Given this list of marker genes NEUROG1, PTCH2, RYR1, ARMC9, NLGN4X, PTEN, SNORD115-1, NOTCH2, HOXD13, TBX5, XRCC4, ALX1, TARS1, ZIC2 (Zic family member 2), NUP85 (NCBI Gene Id 83705), INPP5E, PNPLA6, PRKD1, HNRNPH1, ORC4, GTF2E2, SAMHD1, CD19 (CD19 molecule), EIF4A2, SLC25A12, STAG2, VPS35L, CCDC22, PTCH1, AIP, MAFB, TBCD, BRIP1, TOGARAM1, PEX14 (NCBI Gene Id 5195), KRAS, NSUN2, TGFB3, TLK2, RNF216, CBFB, CHN1, TAF6, SCO2, NRAS, CDKN1C, IGF2, CCDC47, GNPTAB (NCBI Gene Id 79158), PEX6, SLC6A9, PIK3R1, ZDHHC9, TBL1XR1, SON, PPP1R12A, HK1, CDH2, SC5D, CHRNG, DIS3L2, TUBA1A, MADD, PPM1B, GATAD2B, MYCN, DSE (NCBI Gene Id 29940), POLR1C, PRIM1, MEG3, CCBE1, PEX12, HNRNPC, CILK1, FOXF1, POLR3A (NCBI Gene Id 11128), RBM8A, FLI1, PIGO, BRCA2, FRMPD4, MASP1, KDM6A, FLT4, RAB34, ATP7A, D2HGDH, ERCC5, SPTBN1, CEP104 (NCBI Gene Id 9731), DDR2, KMT2E, MAP2K2, HNRNPK, NKX6-2, NAGLU, PDHX, TONSL, ROR2, GNB2, MAP2K1 (mitogen-activated protein kinase kinase 1), SH3PXD2B, LARS1, DICER1, HMGA2, XPC, CSGALNACT1, IFT81, POLE, SUFU, AP1G1, RECQL4, HCFC1, TUBB, MAPK1, COX4I1, TNFRSF11B (TNF receptor superfamily member 11b), NSD2, OTUD6B, ROBO3, GRIA1, FLNB, EHMT1, SALL4, IFT52, CUL7, CDK10, CUX1, PCNT, TOR1A, ACOX1, FOXP2, FERMT1, SLC4A10, SERPINH1, ERCC6, PPP2R1A (NCBI Gene Id 5518), ATR, ADARB1, ATIC, TUBGCP4, CKAP2L, BRD4, B3GALT6, USB1, RREB1, ZFPM2, FUCA1, PEX19, CYFIP2, H4C9, FGFR2, SYT1, CHD5, GYPC, TCTN2 (NCBI Gene Id 79867), SPRTN, LRPPRC, LTBP4, ASH1L (NCBI Gene Id 55870), CHUK, OTUD5, HBA1, CDC45, MYH3, TMEM218, CRPPA, RAB23, SUPT16H, SYNE1, TCF20, PLA2G6, PLEC, ATP6V0A2, PIGN, PIGA, TGFBR2, NDE1, RSPRY1, TDP2, ASPM, MSX2, UPF3B, DPH1, CHD6, DMP1, KNSTRN, TNFRSF11A, IFT43, DPM1, PLK4, CEP57, CNTNAP1, PIGT, ALDH18A1, FTO, ATRIP, HIRA, PPP3CA, NEK1, TCIRG1, MEGF8, CTCF, TRAIP, EIF5A, CACNA2D1, AKT1, ADAMTS3, FANCE, SP7, TAPT1, KDR, KCNK9, NGLY1, TRIP13, MEN1, GABRD (gamma-aminobutyric acid type A receptor subunit delta), CENPE, RUNX2, ZEB2, VANGL2, ERCC3 (ERCC excision repair 3, TFIIH core complex helicase subunit), HSPA9, EZH2, GTF2H5, PAM16, AUTS2, AHDC1, PPM1D, SOX4, IQSEC2, PPP2CA, TBX2, MBTPS2, FANCB, DOCK6, CPLANE1, INTS11, CNTN1, MAP3K7, GET4, MTX2, ARID2, APC, MMP14, ADAT3, TXNDC15, ALMS1 (NCBI Gene Id 7840), YY1, DRG1, UBE3B, KATNIP, WWOX, SPTB, ALG12, FZD2, TUBGCP6, SHANK3, GPR101, TBXAS1, RNF113A, EFTUD2, ADH5, FGFR3, ATP2B1, ZNF699, GATA5, TMEM67 (transmembrane protein 67), EFNB1, PEX16, SMC3, USP7, PREPL, SATB2, NEPRO, DPH2, KRT5, PWAR1, COLEC10, MED27, ADAMTS10, PPIB, CRTAP, IFT56, GPX4, HECTD4, SHOX, ARVCF, PTRH2, TBC1D24, CDC42BPB, FLCN, SPECC1L, C2CD3, RHOBTB2, NLRP3, MKRN3, COL11A1, TMEM231, SETD5, IL6ST, RMRP, OSTM1, TWIST1, TOPORS, KDM5B, HUWE1, GRB10, PCGF2, PRPS1, PIGG, FOCAD, STXBP1, PHEX, TRIP11, MCTP2, LFNG, HSD17B4, FGF9, GPC6, HERC2, APC2, KCNQ1OT1, SLC35D1, HSPG2, RAD21, PPP2R5D, TRPM3 (transient receptor potential cation channel subfamily M member 3), ACTB, RPS19, TGFBR1 (transforming growth factor beta receptor 1), DLX5, AP1S2, WAC, ACTG1, CR2, GLI3, PEX7, SLC26A2, MYMK, DYNC2I1, TMEM70, ORC6, KAT6A, CDT1, GRIA3, ZSWIM6, EOGT, FKBP10, H3-3A, COLEC11, SPOP, SIK3, KCNH1 (potassium voltage-gated channel subfamily H member 1), FANCD2, FLNA, MID1, BMPR1A, SOX2, GALNT2, CEP120, SMAD3, SLC29A3, DDB2, TANC2, TBC1D7, ANKH, ZNHIT3, TRIM37, RTL1, LIG4, DMXL2, SLC35A2, NPR2, EDA, RPGRIP1L, BRCA1, WDR19, NXN, SKIC3, TMCO1, CRELD1, RAB3GAP1, DYNC1H1, NFKB1, MTM1, SLC39A8, BRAF (B-Raf proto-oncogene, serine/threonine kinase), FMR1, TFAP2B, CDK13, MN1, WASHC5, NRCAM, JAG1, WDR73, UGP2, XRCC2, LYN, GDF11, POLR1D, CA2 (carbonic anhydrase 2), COL5A1, CASK, RERE, PWRN1, FH, USP9X, KYNU, IFT74, HNRNPU, KDM5A, TGFB2, ADAR, AARS1, MAF, PEX3, FBN2, POR, RNASEH2C, TGFB1, AFF4, MYSM1, ARL3, PEX13, UGDH, MED12, CTSK, ERCC2, PRKAR1A, SCN4A, DONSON, IDS, TBCE, CD96, LEMD3, PIK3CD, SMOC1 (NCBI Gene Id 64093), SLC12A6, RBBP8, SMAD2, SGSH, SOX5, EBP, POLR1A, HDAC4, KIAA0586, POLR1B, EML1, ARX, KIAA0753, ADAMTSL1, COMT, PGAP3, NFKB2, LUZP1, ACBD6, PRKCZ, ORC1, BAP1, IPO8 (NCBI Gene Id 10526), GNS (glucosamine (N-acetyl)-6-sulfatase), SGMS2, UFC1, PDE4D, WBP4, CBY1, IDUA, RPL10, DLX3, ARCN1, MMP2, AHI1 (NCBI Gene Id 54806), CHST14, NKX2-5, MPDZ, TUBB3, SCNM1, TCTN1, ARL13B, PEX2, ANKRD11, FHL1, PEX26, RAB3GAP2, PTDSS1, FANCA, HEPHL1, TBX1, PAK1, TBC1D20, PCLO, EXOC6B, EXTL3, FRAS1, FBXL4, RAB18, WDR26, PHF21A, CDC6, FAM149B1, DNA2, CTNS, OSGEP, BLTP1, KDM1A, YWHAE, SMG8, SET, NFKBIA, LETM1, TECPR2, HDAC8, DLK1, UBE2T, KIDINS220, GJA5, GJA1, DYNC2I2, AGO2, PGAP2, CAMKMT, SETD1B, ITGB4, NEDD4L, BGN, FGD1, BPNT2, PCDHGC4, SMARCD1, GNPNAT1, B9D2, POLR2A, CNOT1, TNFRSF13B, SETBP1, PALB2, C12orf57, CCNQ, FBXO11, STAT3, PIGW, CPLX1, HYMAI, ATAD3A, ADK, STAC3, PRDM16, KIF21A, AMER1, TNFSF11, GDF1, KMT2C, LTBP1, RAC3, TBX15, CTNNB1, UBR1 (ubiquitin protein ligase E3 component n-recognin 1), KMT2D, KMT2A, GOLGA2, HPGD, PRKAR1B, TCTN3, FANCF, INTS1, CLCN3, LIFR, LMNB2, IRX5, PSAT1, ATRX, RAF1 (NCBI Gene Id 5894), SLC17A5, PIGL, ANTXR1, HES7, RNU4-2, BMS1 (BMS1 ribosome biogenesis factor), SPEN, UBE4B, DHX37, ADSL, CARS1, TTC5, DHCR24, TP53RK, CHSY1, SOST, BUB3, PDPN, ASXL1, PTHLH (NCBI Gene Id 5744), FGFRL1, TMEM216, KIF15, H4C5, COX4I2, TAF1, PPP1R21, MGAT2, KLF1, INPPL1 (inositol polyphosphate phosphatase like 1), ABL1, FANCI, WDR35, CITED2, OCA2, IFT122, CASZ1, TRAPPC9, THUMPD1 (THUMP domain containing 1), RUSC2, HNRNPR, GPC3, ICOS, DNMT3A, AASS, TMEM237, PLCH1, IFIH1 (NCBI Gene Id 64135), BLM, SATB1, PDHA1, OBSL1, KDM4B, ERGIC1, FANCC, MBD5, CREBBP, CHD4, GK, CAMK2A (NCBI Gene Id 815), COG4, GRIN1, ZBTB20, RPS6KA3, CHST3, SNX10, HERC1, CBL (Cbl proto-oncogene), SCARF2, CNTNAP2, PYCR1, KANSL1, CNOT3, INTU, KIT, RAB39B, MTHFR, POGZ, DLL3, VCP, NEU1, ACP5, TBX4 (NCBI Gene Id 9496), CD81, PQBP1, DVL3, HYLS1, SLC39A13, MPLKIP, RTTN, KCNJ2, DPF2, DEAF1, MECP2, ALPL, RNU4ATAC, NSD1, ALDH6A1, TBCK, KIF7, HDAC6, SMC1A, GPC4, SMS, AGA, PHOX2A, CLCN7, SMAD6, SLC2A10, EXT2 (NCBI Gene Id 2132), CCDC8, FGFR1, OCRL, NOVA2, HNRNPA1, HNRNPA2B1, TMEM138, TRAF7, KDM6B, CHAMP1, RNASEH2A, GNAS, GRIP1, SNAP29, NCAPG2, ITCH, WNT5A, ARID1B (AT-rich interaction domain 1B), FLII, RIPPLY2, PEX5, ADNP, HRAS, DHCR7, EMC10, SLC35A1, MED13L, SETD1A, PIGQ, LBR, CYP27B1, JMJD1C, ZC4H2, ANKRD17, IRF2BP2, NELFA, NOTCH3, MVK, B9D1, ARHGAP31, P4HB, PRUNE1, SEC24C, TREX1, CACNA1C, SOX6, PIK3R2, MCOLN1, EXOC8, RFX7, GP1BB, PAFAH1B1, MOCS2, UBA2, SMARCA2, PIBF1, MITF, FREM1, TNFRSF13C, KRT14, FIG4, MSL3, PKDCC, SH2B1, DDX3X, EDARADD, ALG9, MMP23B, FANCM, ZNF148, NFIX, FAT4, NAA10, THOC2, ALG14, KCNQ1, PI4KA, PIGV, COL11A2, PDE6D, FANCG, SMG9, TCOF1, BUB1, RELN, SMAD4, TMEM53, SOX9, ZNF423, VDR, SRD5A3, CWC27, ERI1 (exoribonuclease 1), GBA1, MAN1B1, ZFX, AXIN1, CEP152, SKI, PDGFRB, SLC25A24 (NCBI Gene Id 92093), EPB41, B3GLCT (beta 3-glucosyltransferase), ENPP1, METTL23, SLC39A14, GCSH, HBB (NCBI Gene Id 3043), SLC3A1, DYNC2H1, GNE, CEP41, LAMA5, MAD2L2, RPS23, CYP2R1, NALCN, ZNF142, NTNG2, HBA2, WNT7A, MS4A1, PPP1CB, IFT140, KCTD1, SLC34A3, RNASEH2B, SMO, LONP1, AKT3, HEPACAM, ZMYND11, SEC24D, DPM2, TRPV6, PLAGL1, IKBKG, FBN1, MTOR, ASXL3, SNORD116-1, NKX2-6, SFRP4, ALX4, COL25A1, COL1A2, CREB3L1, LMX1B, TRPS1, CDH11, NUP188, EP300, CEP290, WBP11, B3GAT3, GLIS3, EBF3, RNU12, UFD1 (ubiquitin recognition factor in ER associated degradation 1), PEX10, IL11RA, UBE3A, CHRNA7, IFT80, TCF12, PIK3CA, TFAP2A, GJA8, BMP4, DYM, TTC8, GLB1, JARID2, COL9A2, ITPR1, TET3, PTH1R, SCUBE3, NPHP1, B4GALT7 (beta-1,4-galactosyltransferase 7), XPA, DENND5A, RB1, ACAN, PURA, MEIS2, PEX11B, GATA4, BICRA, COL2A1, NIPBL, RNU7-1, ARHGEF9, FKTN, PAK2 (NCBI Gene Id 9106), DPYSL5, SMC5, EDA2R, PTPN11, SIN3A, CHD1, MPDU1, TIMM50, PEX1, PIGY, DDX6, RNF135, NONO, HGSNAT, RALGAPA1 (Ral GTPase activating protein catalytic subunit alpha 1), KCNJ5, PDHB (pyruvate dehydrogenase E1 subunit beta), DYRK1A, KATNB1, KCNAB2, ERF, H3-3B, DEPDC5, NANS, KCNJ1, MESD, TRIO, ATP6V1B2, RAD51C, MAGEL2, PRMT7, ZIC1, CTU2, FAM20C, MOCS1, EPB41L1, ERCC8, SIX2, P3H1, OFD1, VAC14, GATA6 (GATA binding protein 6), SNX14, ERCC4, SNAI2, CTBP1, ARSB, COL1A1, DPYS, FREM2, FANCL, RAD51, PLEKHM1, EDAR, BRWD3, CHD3 (chromodomain helicase DNA binding protein 3), RFWD3, CSPP1 (NCBI Gene Id 79848), SIX6, ZMPSTE24 (zinc metallopeptidase STE24), CYP26B1, UNC80, COX5A, RAI1, KIF11, POLD3, ESCO2, POLA1, NAA20, DVL1, LRP4, MESP2, NBAS, TNFSF12, LSM11, SEC23A, KPTN, MKS1, MOGS, LMNB1, SLX4, PLAG1, PAICS, CC2D2A, KMT2B, PHF6, PSMC1, CUL4B, SCYL2, ERMARD (NCBI Gene Id 55780), DDX59, KAT6B, BUB1B, COL18A1, RBPJ, TAF8, CRIPT (NCBI Gene Id 9419), LRP5 (LDL receptor related protein 5), DLL4, MAN2B1, SPTA1, TRIP12, NFIA (NCBI Gene Id 4774), SNRPN (NCBI Gene Id 6638), ZNF292, TBX6, NOTCH1 (NCBI Gene Id 54781), NPAP1, GMNN, OPHN1, RNPC3, PLOD1, POU1F1, RAC1, TUBB2B, here is a description of the gene set: Abnormal calvaria morphology species: Homo sapiens Abnormality of the morphology (structure) of the calvaria (skullcap), that is, of that part of the skull that is made up of the superior portions of the frontal bone, occipital bone, and parietal bones and covers the cranial cavity that contains the brain. Human Gene Set: HP_ABNORMAL_CALVARIA_MORPHOLOGY